The following is a description of a gene set: Human Gene Set: HP_CHRONIC_NONINFECTIOUS_LYMPHADENOPATHY Chronic noninfectious lymphadenopathy A chronic form of lymphadenopathy that is not related to infection. species: Homo sapiens, and this is the list of marker genes: CASP10, ATRX, HABP2, MINPP1, FASLG (NCBI Gene Id 356), FAS, ABCA1, FOXE1, SDHD